Given this list of marker genes Tmem150b, Zfp236, Tal1, Phldb1, Zmiz2, Nr5a1, Mapk8ip1, Smg7 (SMG7 nonsense mediated mRNA decay factor), Chrm1 (NCBI Gene Id 12669), Praf2 (NCBI Gene Id 97593), Fbxo41, Dvl3, Pax9, Rapgef1, Hyou1, Pml, Nptx1, D130043K22Rik, Lin54, Fmod, B4galt2, Pnpla3, Map6, Slc7a5, Tlcd3b, Nckipsd, Samd4b, Tomm40l, Ppard, Becn1, Smtnl2, Suv39h1, Ntsr1, Kcnk3, Wscd2, Usp21, Lhfpl2, Zfp46, Ptpru, Pigm, Ptprn, Zfp592, Ehd1, Mboat4, Pde1b, Mapk8ip3, Foxp3, Ece1, Pdgfrb, Prr5, Thbs3, Vash1, St3gal1, Vipr1 (NCBI Gene Id 22354), Veph1, Cs, Chga, Ces3a, Map1a, B3gat3, Katnip, Trarg1, Vat1, Slc35f6, Sec61a2, Plk2, Znrf1, Add1, Jrk, Cluh (NCBI Gene Id 74148), Zfp384, Cbfa2t3, Ccdc71l, Arhgap36, Arhgap1, Klhl26, Rnf13, Ehd3, Pom121, Foxp4, Ctif, Cfl1, Flrt1, Fev, Sun2, Adcy1, Uncx, Tbx4, Cdh16, Cops6, Irf2bpl (NCBI Gene Id 238330), Vamp2, Car7, Cpa3, Cd46, Chst4, Stard10, Inpp5b, here is a description of the gene set: species: Mus musculus Mouse Gene Set: MIR_185_3P from publication Chen Y, Wang X (PMID 31504780) Genes predicted to be targets of miRBase v22 microRNA mmu_miR_185_3p in miRDB v6.0 with MirTarget v4 prediction scores > 80 (high confidence targets).